The following is a description of a gene set: studied in species Homo sapiens Human Gene Set: HP_AORTOPULMONARY_COLLATERAL_ARTERIES Aortopulmonary collateral arteries Small ectopic arteries or arterial branches that connect the aorta, aortic branches and/or subclavian artery regions directly to the lung parenchyma, usually seen in conjunction with pulmonary atresia, ventricular septal defect (VSD) and/or closed ductus arteriosus., and this is the list of marker genes: YY1, SCN1A, SLC25A22, SCN2A, TBC1D24, KCNQ2, ALDH1A2, PLXND1, GDF1, PLCB1, PIGA, PKD1L1, KCNT1, FLT4, SLC12A5